Given this list of marker genes SPON1, FRMD4A, KCNQ2, SPATA1, FOXK1, PACSIN2, VAMP7, NETO1, MB, FBXL3, SMPD3 (sphingomyelin phosphodiesterase 3), RTCA, IMMT, SLC43A2, GPC5, SETX (senataxin), NCDN, NRG2, ACOX1, PLS3, NEK6, ADK, CYP20A1, DENND5A, TRIM5, PARVA, STAG1, ZNF623, CYCS, AFF4, TMCC3, BOK (BCL2 family apoptosis regulator BOK), GFI1, MAML2, CSRP1, ESRP1, ZNF275, HMX2, TPH1, IGF1R (insulin like growth factor 1 receptor), AGER, CZIB, DCC, ARID1A, TRAM1, POP1, CXCL13, RIDA, EPB41L5, PPP1R16B, CRTAP, CPPED1, ZNF750, CYP4Z1, SLC19A3, ZNF713, ABR, FBXO32, YTHDC1, IGSF23, here is a description of the gene set: from publication Chen Y, Wang X (PMID 31504780) studied in species Homo sapiens Human Gene Set: MIR3934_5P Genes predicted to be targets of miRBase v22 microRNA hsa-miR-3934-5p in miRDB v6.0 with MirTarget v4 prediction scores > 80 (high confidence targets).